The following is a description of a gene set: from publication Chen Y, Wang X (PMID 31504780) studied in species Homo sapiens Human Gene Set: MIR4685_3P Genes predicted to be targets of miRBase v22 microRNA hsa-miR-4685-3p in miRDB v6.0 with MirTarget v4 prediction scores > 80 (high confidence targets)., and this is the list of marker genes: TMEM242, ADCY1, ZDHHC22, DUSP6, HS1BP3 (NCBI Gene Id 64342), TOX2, APLN, CFAP97, RAB11A, KPNA1, FRMD5 (FERM domain containing 5), ZNF384, PLCB1, INTS8, AP1AR, KLHL42, TIE1, TACC2, NTRK2, ASIC1, AGO4, TRHR, NUP88, RECK, TAF1C, NBN, DDX3X, BTN3A1, NCAN, BMP2K, MAP1A, HNRNPUL2, CCR2, ENPP3, ZNF506, DKK2, PTGER3, RGCC, MS4A6A, SLC22A5, RCC1, EDEM1, MAP2K4, TMEM121B, ESRP1, UPRT, EPC1, VAPB, LYZ, RPL28, FAM117B, KPNA6, ATG9A, ZNF135, PHF23, TGFB3, MAP2K6, XCL1, EOMES, DTX4, RAP2A, TOB2, BARX2, RIPK1, CPD, KIAA1210, EHF, TMOD3 (tropomodulin 3), SPATA13, SAYSD1, CSPG4, ICE2 (interactor of little elongation complex ELL subunit 2), ZNF600, LTBP1, EFEMP2, ACSM2B, TOP1, MAP4K5, PMEPA1 (prostate transmembrane protein, androgen induced 1), ZNF780B, S1PR1 (sphingosine-1-phosphate receptor 1), SRP54, ROBO2, SEPTIN6, NDST3, TRAF2, TRIQK, SMG7, NUDT13, PRAME, KCNQ3, SNX31, QKI, CAPN15, KRT80, DCC, CDKL5, POU2F1, SEC22B, TMOD2, HOXA10, EPHA7, DDAH1, CREB5, NUAK1, SPEG, ADRA1A, PTHLH, RP2, ADCY3, KLF12 (NCBI Gene Id 82238), ZNRF3, FNDC9, VBP1, RFX5, HMGA2, EDN1, FSD1L, KAT5, NAA16, SOX11, ZNF71, STYK1, INO80D, LRP12, GPR161, TAF5 (TATA-box binding protein associated factor 5), STK38L